The following is a description of a gene set: A neoplasm that affects the female reproductive system. species: Homo sapiens Human Gene Set: HP_FEMALE_REPRODUCTIVE_SYSTEM_NEOPLASM Female reproductive system neoplasm, and this is the list of marker genes: PDGFRL, SEMA4A, ATM, BMPR1A (bone morphogenetic protein receptor type 1A), BUB1, GREM1, CDH1, MSH6, MUTYH, MCC (NCBI Gene Id 4163), CHEK2, PMS2, RAD54B, POLE, AXIN2, LZTR1, SDHC, DLC1, STAT6, SLC6A17, AURKA, SMARCB1, PTPN12, CDC73, SRC, COQ6, CCND1, KLLN, BAX, SDHB, APC, TGFBR2, TLR2, FLI1, MLH1, BRCA2, MSH3, DOCK8, PLA2G2A, PIK3CA, BUB1B, POLD1, CEP57, RPS20, KRAS, MLH3, SEC23B, BUB3, AKT1, TP53 (NCBI Gene Id 7157), STK11, COL4A5, NTHL1, PTPRJ, FLCN, TRIP13, CTNNB1, EP300, COL4A6, FH, BRAF, NF2, PMS1, NAB2 (NGFI-A binding protein 2), NRAS, SDHD, EPCAM, PTEN, MSH2, USF3, DCC (NCBI Gene Id 1630), FGFR3